Given this list of marker genes CD79B, PTGIR, LILRA5, IFITM1, CDC42EP2, HK3, CDKN1C, CD300E, GCH1, APOBEC3A, FCGR3A, PELATON, GBP2, LILRA1, TCF7L2, BIRC3, CLEC12A, here is a description of the gene set: species: Homo sapiens from publication He P, Lim K, Sun D, Pett JP, Jeng Q, Polanski K, Dong Z, Bolt L, Richardson L, Mamanova L, Dabrowska M, Wilbrey-Clark A, Madissoon E, Tuong ZK, Dann E, Suo C, Goh I, Yoshida M, Nikolić MZ, Janes SM, He X, Barker RA, Teichmann SA, Marioni JC, Meyer KB, Rawlins EL (PMID 36493756) Human Gene Set: HE_LIM_SUN_FETAL_LUNG_C2_NON_CLASSICAL_MONOCYTE Non-cla. mono.